The following is a description of a gene set: studied in species Homo sapiens Human Gene Set: GOBP_ENDOPLASMIC_RETICULUM_MANNOSE_TRIMMING Any protein alpha-1,2-demannosylation that takes place in the endoplasmic reticulum quality control compartment (ERQC)., and this is the list of marker genes: UGGT1, RNF139, MARCHF6, SYVN1, EDEM2, RNF103, MAN1B1, EDEM1, EDEM3, TRIM13, RNF5, RNF185, AMFR, UGGT2